The following is a description of a gene set: studied in species Mus musculus Any process that activates or increases the frequency, rate or extent of opsonization. Mouse Gene Set: GOBP_POSITIVE_REGULATION_OF_OPSONIZATION, and this is the list of marker genes: Colec11, Fcnb, Mbl2, Cfp, Colec10, Pla2g5, Myo18a (NCBI Gene Id 360013)